Given this list of marker genes CUX1, PURA, DOCK3, PLAG1, FGD4, GUCY1A2, TPRKB, ANK3, NEUROD1, HCFC2, CARF, SLC16A7, KRT28, SEM1, ARID3A, DLX1, ZNF117, EVA1A, ABI3BP, ZNF236, BEND6, POU2F1, SLC23A2, APCDD1, MLLT10, PPM1A, DCAF17, RUNX1T1, ELK4, PKHD1, PPM1K, MRPL35, SV2C, TMEM168, CYP1B1, VBP1, RAB39B, RALGAPA2, SCRN3, DACH1, IL18BP, SINHCAF, MIPOL1, RAB22A, RIOX2, CAT, FASTKD1, POU4F1, POTEM, EIF4EBP2, NFKBIZ, RAB3B, SNX10, CEBPB, PTPRQ, LGR5, INO80D, POU2F3, PRPF38B, TNRC18, STXBP5, PCMTD2, AVL9, NDST3, PHACTR2 (NCBI Gene Id 9749), FBXO32, GPBP1, ARID2, RANBP6, VGLL3, NSG1 (neuronal vesicle trafficking associated 1), RRAGC, FOS, FZD7, SMARCA1, EHF, RHNO1 (NCBI Gene Id 83695), COL5A1, COMMD3, S1PR3, GABRG2, POTEA, LARP4, ADD3, ZBTB41, CD180, RAB21, GBP4, POGLUT3, ANKRD20A1, CCDC9B, HUWE1, TRAK2, RBM20, GPR63, CAND2, MECOM, ATP6V1C2, YPEL2, PCDH9, ZNF41, KCNA7, PPP1R3E, MFHAS1, RBM47, TNC, CFAP97D1, IFIT5, RBM41 (NCBI Gene Id 80171), HSCB, GXYLT1, NAV2, UGT2B15, DCAF10, MAGEE1, TTL, C5orf63, SIX4, MBNL1, H6PD, ANKRD20A2P, FAXC (failed axon connections homolog, metaxin like GST domain containing), ZMYND8, ANKRD29, DCLK1, PCARE, LAIR1, ZSCAN31 (zinc finger and SCAN domain containing 31), VPS41, ST3GAL4, PWWP2B, SOCS4, ZNF331, HTR1B, RALYL, SLC4A8, SLC35F3, CSNK1G1, ERGIC2, NPAS2, ZDHHC3, RAB30, WDR72, RAB29, SCN11A, SLC35F6, DTNB, PTP4A2, PHIP, FXR1, ZNF652, COL8A1, RGS20, TNRC6B, ABCD2, CEACAM5, AAK1, ZMAT1 (NCBI Gene Id 84460), F11R, PEX12, PIN4, ABCA5, FAM53B, SPAG9, HOPX, ANKRD45, LDB2, SSPN, NMT2, MLLT6, TBL1X, TTC14, RORB, UNC13C, PCDH17, PAX6, PCGF5, SLC24A2, ZBTB20, TRPM7, RBM14, CLVS2, SPRED1, FER, NR4A3, ZZZ3, LHFPL2, GINS3, ANKRD20A3P, ADARB2, FKTN, ANKRD12, CDH1, SLC44A1, GPR26, SERINC4, RBM26, MAP3K2, ARHGAP32, LPP, MGP, SLC25A46, ARMC8, TLR4 (toll like receptor 4), SLC5A12, HS3ST3B1, CAPZB, PLEKHG1, DDX42, TOGARAM1, UBN2, RASEF, CGGBP1, AKNA, RNF41, ADAM22, ZBTB11, PM20D2, LRRC4C, DZIP3, ARHGAP26, NIN, INTS6, BNC2 (NCBI Gene Id 54796), PCF11, GNAQ, SNX18, CACNA1E, NAV1, RALA, DSP, CCNT1, EIF4E3, DMTF1, SYT4, AKAP6, HTR1D, KIF20B, MAGI3, ALKBH1, PRKCQ, RANBP3L, TLCD4, UTRN, CSGALNACT1, CANX (NCBI Gene Id 821), RNF169, LIN54, LCORL, MSRA (NCBI Gene Id 4482), AFF4, ZNF793, ST3GAL1 (NCBI Gene Id 6482), DDI2, ZNF329, DNAH14, ADAMTS18, THSD7A, TRPC5OS (NCBI Gene Id 100506619), FBXW7, KIAA1549L, C1orf21, ELOVL6, NLN, C1GALT1, STX11, ZDHHC17, PALM2AKAP2, AGPS, EPHA3, USF3, ZNF333, DPP8, SLC25A15 (solute carrier family 25 member 15), CAMK4, MSL1, MTR, IL1RAP, DDHD1, DENND1B, ONECUT2, BORCS7, PSD3 (NCBI Gene Id 55358), PCDH11Y, KLHL24, TMC5, POGK, FOXO1, NID1, PRR11, NUFIP2, RAB14, SKIL, FCRL4, CNOT4, MALT1, LUM, CREG2, GRB14, KEAP1, OPN3, NWD1 (NCBI Gene Id 284434), ATRX, SLC6A5 (NCBI Gene Id 9152), HOXB3, TNFSF10, MAML1, SEMA6A, ZNF407, BTG2, TERF2IP, ADGRL2, SEZ6L, ESRRB, KRT13, ANKRD20A4P, DIO2, CAMK2N1, KCTD14, AFG2A, SYNJ2BP, PTPN3, GATA3, AKR1D1, CD2AP, MUS81 (NCBI Gene Id 80198), GABRA4, SAMD12, G6PC1, SGIP1, RNF128 (ring finger protein 128), TBC1D8B, AK9, SARNP, ADAT2, SEMA3D, FMN1, BIRC2, NDUFC2-KCTD14, MICU3, ATRN, MYO6, JADE2, ZIC1, SEMA5A, PPP5D1P, TSNAX, SRSF4, SATB2, CEP55, C2CD4A, IL1RN, KMT2A, RAB7A, KRAS, SLC2A12, EIF3E, CPE, DHX40, RPL15, GRK3, ZFP90, LCTL, FRYL, CELF5, CLSTN2, RAD9A, IGF1R, UNC5D, PDPK1, IGF1, ILDR2, KCNMA1 (potassium calcium-activated channel subfamily M alpha 1), COL27A1, DDX21, ZMIZ1, PDLIM5, RTKN2, CALN1, CD55, FAT3, NSL1, CCDC88A, GBP7, H2BC21, TENM4, PAK3, MAP7, CAMLG, PAG1, TBL1Y, CCNT2 (NCBI Gene Id 905), IRAK3, ARRDC4, FBXO45, ROR1, CISD2, SRPX, ZC3H18, ATP11AUN, PCDH11X, USP46, QKI, GALNT13, HLF, ALG10B, LRRTM2, ZNF695, ADAMTS3, LRRN1, MBNL3, GLS (NCBI Gene Id 51679), NR2C2, ZDHHC21, COL24A1, DGKH, SNX16, PTN, EIF2A, PHF21A, TMEM74, JAZF1, IL32, CPNE3, ENDOD1, ERAP2, ATG7, CACNB1, VEGFB, TMX3, WDR93, CPEB4, DYRK1A, VNN3P, JKAMP, EBI3, SMAD7, PIAS1, RALGAPB, USP47, GRIA3, CDK6, PDIK1L, ZNF704, CMYA5, SLA, NXPE3, TUBB, C3orf33, PDLIM2, CPPED1, OSBPL8, PIK3CA, CNKSR3, PWWP3B, NEXMIF, B3GNT5, GTDC1, KCNT2, SIPA1L1, SLC39A14, WDFY2, SASH1 (SAM and SH3 domain containing 1), FDX1, ROBO2, ATXN1, TLN2, CIPC, ANAPC10, GAB3, COPS3, here is a description of the gene set: species: Homo sapiens Genes predicted to be targets of miRBase v22 microRNA hsa-miR-627-3p in miRDB v6.0 with MirTarget v4 prediction scores > 80 (high confidence targets). from publication Chen Y, Wang X (PMID 31504780) Human Gene Set: MIR627_3P